Given this list of marker genes MT-CYB (NCBI Gene Id 4519), CYC1, UQCRH (ubiquinol-cytochrome c reductase hinge protein), UQCRC1, UQCRFS1, UQCR10, UQCRFS1P1, here is a description of the gene set: studied in species Homo sapiens Enables the transfer of a solute or solutes from one side of a membrane to the other according to the reaction: CoQH2 + 2 ferricytochrome c = CoQ + 2 ferrocytochrome c + 2 H+. Human Gene Set: GOMF_UBIQUINOL_CYTOCHROME_C_REDUCTASE_ACTIVITY